The following is a description of a gene set: Human Gene Set: MIR6839_3P species: Homo sapiens from publication Chen Y, Wang X (PMID 31504780) Genes predicted to be targets of miRBase v22 microRNA hsa-miR-6839-3p in miRDB v6.0 with MirTarget v4 prediction scores > 80 (high confidence targets)., and this is the list of marker genes: TCP10L2, LZTS2, GAB1, EIF5AL1, YY1, ZNF134, GPX3, LETM2, TRIL, RSU1, PPM1N, ACAT2, MAML2, PTCHD4, IQCH, KAT6A, UGT1A8, RIMBP2, EML5, FAF2, TXNDC5, PRR12, MS4A1, TEAD4, RTN4RL1, SLC12A5, RALYL, ALCAM, ZNF322 (NCBI Gene Id 79692), TMEM9B, HSPB2, SLC16A9, MMP16, MIEF2, UGT1A10, JAM3, MAP3K8, CHST11, BRCA1, MARCHF6, HECW1, CABP4, AMOTL1, SYCE2, FNDC5, PPP4R4, CCDC32, UGT1A3 (UDP glucuronosyltransferase family 1 member A3), BMP2K, CALD1, DHX57, TMEM106B (transmembrane protein 106B), NUP88, GAD2, CDC37L1, TMSB15A, PLEKHA6, MTRF1L, PRLR, GPR6, MYH11, SNX18, EFCAB5 (EF-hand calcium binding domain 5), COL5A1, DISC1, CBLL1, CAV1, HOXA1, COL4A2-AS2, IGSF6, SPRED3, POLR3F, UNC5C, UBR3, EFR3B, LSM12, VASH1, TXLNB, TAX1BP1, ILDR1, LRP6, CEBPG, ATG5, AMDHD1, AKT3, FOXK2, TCF4, UGT1A9 (NCBI Gene Id 54600), ECT2, FRZB (frizzled related protein), GTF2A2, ANGPTL1, TSTD2, SLC25A3, WIPF2, UVRAG, MCM3, SPRY3, TNRC6C, UGT1A4, NR3C1, KIAA0753, CNBP, GTF2F2, GLTP, VPS54, COL1A2, MED13L, NUTF2, CDYL2, HYCC1, UGT1A1, METTL9, VDAC3, RASSF8, SUSD5, CFAP47, RHNO1, TMEM154 (NCBI Gene Id 201799), ELAVL4, AZIN1, PRRX1, NANOS1, XKR4, TRIM33, CD24, ATXN1, CHRNA9, ADAM12, UGT1A5, UGT1A7, UGT1A6, ERGIC2, LUC7L2, SDCBP, ZNRF3, PIKFYVE, KLHL7, ZFYVE28, TCAF1, RBFOX1 (NCBI Gene Id 54715), ATXN7L3B, DENND5B, MEIOC, PRRG1, HNF4A, RFX4, METTL13, ENSA, MAPK10, MAB21L2, TENM3, MMP21, TSHZ1, DDX42, PCDHA9, FMC1-LUC7L2, ONECUT2